The following is a description of a gene set: Human Gene Set: GOBP_POSITIVE_REGULATION_OF_PROTEASOMAL_PROTEIN_CATABOLIC_PROCESS studied in species Homo sapiens Any process that activates or increases the frequency, rate or extent of proteasomal protein catabolic process., and this is the list of marker genes: RNF180, BCAP31, CBFA2T3, GCLC, ECSCR, DAB2IP (NCBI Gene Id 84635), SH3RF3, MDM2 (MDM2 proto-oncogene), ATXN3, TMTC3, NKD2, SGTA, HSPA1B, NUB1, STUB1, UBQLN1, PSMC6, SH3RF2, BAG6, RFPL1, RACK1, ZER1, PSMC1, TRIB3, RNFT2, SUMO1, RNFT1, CDC20B (NCBI Gene Id 166979), MAPK9, KCNE2, PRKN, PLK1, DDA1, PLK3, ZYG11B, PRICKLE1, AXIN1, PSMC5, ATXN3L, FZR1, SOCS5, BBS7, RBX1, CHFR, GSK3A, TREM2, XBP1, TAF1, DAB2, TRIB2, CDC20, FBXW7, CSNK1D, IL33, OSBPL7, NUPR1, HAMP, GBA1, FMR1, PIAS1, DNAJB2, NFE2L2, PSMC3, USP5, PSEN1, NEURL3, PAQR3, SIRT2, HSPA1A, WFS1, TRIB1, CLU, USP13, VCP, AURKA, PABIR1, TMX1, UBQLN2, CEBPA, TF, NOP53, LRRK2, CSNK1E, GABARAP, GSK3B, AXIN2, PSMD10, RNF185, SH3RF1, SOCS4, DVL1, SIRT1, KEAP1, TMEM259, DDRGK1, ELOB, DET1, HSPBP1, PSMC4, ZFAND2A, HERPUD1, SMAD7, CSNK1A1, HECTD1, RCHY1, FBXO22 (F-box protein 22), SIRT6, CAV1, RAD23A, COP1, BAG2, AKT1, FBXW8, PSMC2, SUMO2 (NCBI Gene Id 6613), KLHL40